Given this list of marker genes PSMD14, DDX3Y, ASB6, SLC30A4, CTPS1, RAB18, PIK3CA, MTDH, YTHDF3, SLC7A7, MAP3K8, CRKL, SNTB2, LRRC58, ZNRF1, LCP2, MMP14, TAX1BP1, MDM2, ERRFI1, G3BP1, PLAT, DLD, PTGES, SOCS1, HK2, PDGFA, CALCRL, CYFIP1, SCAMP1, KDELR3, PPP1R15B, TARDBP, ACSL1, NAA15, HNRNPK, HSPA1B, EIF4G1, IER2, MT2A, GCH1, BCL2A1, MMP10, ACOD1, PSMA6, N4BP1, NEK6, PLEKHA1, VASP, RALA, KPNA3, CCL13, PROCR, FNDC3A, PPP1CB, GJA1, PDPN, HSPD1, IST1, GPC4, EFNB2, SLC11A2, KLF3, AGFG1, ZNF207, CEBPD, SSB, EXT1, RBM18, STAT5A, MAPRE1, ELOC, JUNB, JAK2, IL4R (interleukin 4 receptor), ADAM9, DUSP2, PNO1, MFSD14A, SLC31A1, PFKFB3, LRP10, ARHGEF3, ILF3, HNRNPH1, BHLHE40, DNAJB6, TES, RAB12, NFKBIB, GBP7, TLE3, ZFP62, HIF1A, UBE2N, WDR77, VCL, MRPL52, PPIC, AEBP2, CSNK1A1, CDKN1A, GLIPR2, IGF2BP1, MOB1B (MOB kinase activator 1B), PLA2G4A, PTGS2, SLC25A17, SRGN (serglycin), RHOB, TSR1, PLAUR, CD14, TNFSF9, IFRD1, IL1A, IL1B, ICAM1 (intercellular adhesion molecule 1), KCTD12, UPP1, RIOK3, RHOQ, TXNRD1, RELB, SEPTIN2, PAK1IP1, CCND2, OTUD5 (NCBI Gene Id 55593), SERTAD1, MARCKSL1, NOTCH2, LCN2, ABRACL, DSTN, NPY1R, CLCN5, TOP1, SOCS3, FBXW11, STK40, SERPINB2 (NCBI Gene Id 5055), HSP90AA1, MAP2K4, TAB2, TRA2B, GADD45B, GTPBP4, NUPR1, CAV1, DNAAF10, PIM1, MMP13, SERPINE1, UFM1, MAP3K5, SLK, MAP4K4, RAB10, ACSL4, SOWAHC, EIF1AY, IL10, KCMF1, UGCG, IFNAR1, SNX10, MTMR14, MSR1, NFKBIZ, MCOLN2, APAF1, RNF19B, C9orf72, SLC39A4, ABR, PHOX2A, CXCL2 (C-X-C motif chemokine ligand 2), PBRM1, WTAP, MYADM, MMP12, DUSP16, SELP, NOP58, B4GALT3, LDAF1, SH3GL1, PELI1, RNF103, CLEC4D, NFKB1, BIRC3, DDX5, IL15, IL1RN, LPAR1, EHD1, TNFAIP2, UTP4, TANK, here is a description of the gene set: from publication Toker A, Engelbert D, Garg G, Polansky JK, Floess S, Miyao T, Baron U, Düber S, Geffers R, Giehr P, Schallenberg S, Kretschmer K, Olek S, Walter J, Weiss S, Hori S, Hamann A, Huehn J (PMID 23420886) studied in species Homo sapiens We investigated at which stage of maturation commitment to a stable Foxp3-expressing phenotype takes place. We assessed stability of Foxp3 expression in thymic Foxp3+ Treg subsets of different maturity, defined by CD24 expression. Next we compared gene expression profiles of Foxp3+ Treg subsets (+) of different maturity (24lo, 24int, 24hi) and could identify a set of genes that were specifically up or downregulated in Foxp3+ Tregs, but not in Foxp3- conventional T cells, in a maturation-dependent manner. Genes up-regulated in T reg: peripheral lymph nodes versus thymic CD24 int. Human Gene Set: GSE42021_TREG_PLN_VS_CD24INT_TREG_THYMUS_UP